The following is a description of a gene set: from publication Chen Y, Wang X (PMID 31504780) Genes predicted to be targets of miRBase v22 microRNA mmu_miR_669p_3p in miRDB v6.0 with MirTarget v4 prediction scores > 80 (high confidence targets). Mouse Gene Set: MIR_669P_3P studied in species Mus musculus, and this is the list of marker genes: Plekhm2, Smap1, Dlat, Pomp, Tmem19, Frzb, Chek1, Pdgfra, 4930444P10Rik, Cnbp (NCBI Gene Id 12785), Wdr44, Hook3, 9330182O14Rik, Rpgrip1l, Inpp4b, Ccdc42, Kat6a, Msi2, Dlx5, Oprm1, Trdmt1, Arxes1, Spdye4a, Zfp239 (NCBI Gene Id 22685), Ets1, Pakap, Armc8, Dhx15, Mill1, Tdrd3, Sdr42e1, Dlg1, Sult1d1, Gnai1, Qki, Ptbp3, Acyp2, Cttnbp2nl, Ddit4l, Srsf2, Aqp4, Vwa5a, Trub1, Pde4b, Itga2, Slc8a1, Pak3, Dach1, Zfp384, Rcn2, Stam, Ppp1r3c, Ube2e3, Dmxl1 (NCBI Gene Id 240284), Unc5d (unc-5 netrin receptor D), Zbtb33, Akap5, Rbm12b2, Eya3, Scai, Bend4, Cgas, Pfdn4, Txk, Rhox3a, Gse1, Bmpr2, Rapgef2, C4bp, Pcsk5, Trappc3l, Itgb1, Nfxl1 (NCBI Gene Id 76396), Pou2f1, Lancl1, Slc35g2, Cpeb3, Car2 (carbonic anhydrase 2), Smc5, Pate12, Galnt13, Fgd6, Jag1, Cdh11, Gpr174, Oxr1, Med14, Gdf6, Zbtb41, Rps6ka6, Eps8, Trabd2b, Tnrc6b, Usp33, Tmem108, Rhou, Trp53bp1, Mphosph6, Cadm2, Fndc3b, Rhox3f, Tbc1d8b, Cyp26b1, Gpr155, Fut9, Phip, Zdhhc17, Ntrk2, Ufl1, Ube2w, St8sia4, Xcl1, Pabpc4l, Rhox3c, Lrpprc, Ubn2, Wdr82, Arid2, Fasl, Ccl20, Spsb3, Scg2 (secretogranin II), Phyhipl, Actr3b, Il6, Rhox3h, Gadd45gip1, Rreb1, Nipa2, Pax6, Orc6, Npy5r, Zeb2, Rassf6, Enpp4, Tpmt, Nab1, Chpt1, Pou3f1, Fgb, Zic3, Cep57l1, Myo1g (NCBI Gene Id 353209), Nfat5, Plaa, Ap4e1 (NCBI Gene Id 99266), Arx, Rhag, Raph1, Acvr1c, Lrp11, Ift80, Mtus1, Fgf7, Tc2n, Cbx8, AI182371, Smad7, Pabir1, Dnal1, Dctn6, Mycbp, Nr3c1, Cdk19, Relch, Fgf12, Yipf4, Rufy2, Cep170